The following is a description of a gene set: species: Homo sapiens Human Gene Set: GOBP_POSITIVE_REGULATION_OF_TRIGLYCERIDE_METABOLIC_PROCESS Any process that increases the frequency, rate or extent of the chemical reactions and pathways involving triglyceride, any triester of glycerol., and this is the list of marker genes: KAT5, DAGLB, CNEP1R1, PNPLA2, LDLR, SLC27A1, AADAC, MFSD2A, APOC2, ABHD5, CTDNEP1, SREBF1, DGAT2, MIR29B1, FUT1, GPLD1, APOA5, PLIN5, NR1H2, APOA4, SCARB1, NR1H3, APOH